Given this list of marker genes CLU, TAF9, SIRT1, RPS3, RAD9A, CDKN2D, ELL3, TP73, TMEM161A, FBH1, ING2, DDIAS, BCL2, RPL26, TPT1, BCL2L12, SNAI2, CXCL12, TRIM32, CD74, MIF, NACC2, MTCH2, HNRNPK, SFRP2, ZNF385A, USP47, ACKR3, TRIAP1, KDM1A, CCAR2, MUC1, ATAD5, SNAI1, SKIL, TAF9B, MARCHF7, CD44, PIAS4, BID, BCL2L1, here is a description of the gene set: Human Gene Set: GOBP_REGULATION_OF_INTRINSIC_APOPTOTIC_SIGNALING_PATHWAY_IN_RESPONSE_TO_DNA_DAMAGE studied in species Homo sapiens Any process that modulates the frequency, rate or extent of intrinsic apoptotic signaling pathway in response to DNA damage.